The following is a description of a gene set: part of: Prolonged ERK activation events Reactome Pathway: ARMS-mediated activation ARMS (Ankyrin-Rich Membrane Spanning/Kidins 220) is a 220kD tetraspanning adaptor protein which becomes rapidly tyrosine phosphorylated by active Trk receptors. ARMS is another adaptor protein which is involved in the activation of Rap1 and the subsequent prolonged activation of the MAPK cascade. species: Homo sapiens, and this is the list of marker genes: RAP1A, YWHAB, CRK, NTRK1, BRAF, KIDINS220, NGF